Given this list of marker genes Slc25a33, Vcp, Ak4, Slc25a23, Mlxipl, Atp7a, Pde2a, Dnajc15, Myog, Tnf, Ppif, Rhoa, Shmt2, Myc, Uqcc2, Nupr1, Actn3, Apoc3 (apolipoprotein C-III), Macroh2a1, Tefm, Tmem135, Abcd1, Pink1, here is a description of the gene set: Any process that modulates the frequency, rate or extent of the chemical reactions and pathways resulting in the phosphorylation of ADP to ATP that accompanies the oxidation of a metabolite through the operation of the respiratory chain. Oxidation of compounds establishes a proton gradient across the membrane, providing the energy for ATP synthesis. species: Mus musculus Mouse Gene Set: GOBP_REGULATION_OF_OXIDATIVE_PHOSPHORYLATION